Given this list of marker genes B4GALT6, B3GNT3 (NCBI Gene Id 10331), PLOD3, B4GALT3, B3GALT6, B4GALT5, B3GNT7, C1GALT1C1L, UGT8, B3GALT5, A4GALT, ABO, C1GALT1, COLGALT2, B3GNT4, B3GALT1, CERCAM, COLGALT1, LALBA, B4GALT1, B3GALNT1, B3GNTL1, B4GALT7, B4GALT4, A3GALT2, B3GNT5, B3GNT6, B3GALT4, B3GNT8, B4GALT2, B3GNT2, B3GALT2, C1GALT1C1, here is a description of the gene set: Human Gene Set: GOMF_GALACTOSYLTRANSFERASE_ACTIVITY Catalysis of the transfer of a galactosyl group to an acceptor molecule, typically another carbohydrate or a lipid. studied in species Homo sapiens